The following is a description of a gene set: studied in species Mus musculus Any process that stops, prevents, or reduces the frequency, rate or extent of exocytosis. Mouse Gene Set: GOBP_NEGATIVE_REGULATION_OF_EXOCYTOSIS, and this is the list of marker genes: Gnai2, Atp9a, Vps4b, Braf, C9orf72, Syt4, Ceacam1, Snca, Lgals9, Spi1, Rap1b, Il1rapl1, Rap1a, Hmox1, Pou5f1, Foxf1, Cbarp, Prkn, Adra2a, Rabgef1, Wdr41, Stxbp3, Cd84, Bcr, Notch1, Abr, Tcp11, Trim9, Il13ra2, Rab33b, Anxa1, Rest, Ccr2, Nckap1l, Fmr1, Rab7, Smcr8, Cd300a